Given this list of marker genes Coro1b, Cfl1, Copa, Ednra, Rab13, Ripor2, here is a description of the gene set: A process in which a protein is transported to, or maintained in, a location within a cell leading edge. studied in species Mus musculus Mouse Gene Set: GOBP_PROTEIN_LOCALIZATION_TO_CELL_LEADING_EDGE